Given this list of marker genes ADCY5, CAP2, CALM2, ADRB2, CALM3, ADCYAP1R1, AKAP6, AKAP5, CAP1, GRIA1, ADCY2, AKAP12, here is a description of the gene set: species: Homo sapiens Human Gene Set: GOMF_ADENYLATE_CYCLASE_BINDING Binding to an adenylate cyclase.